The following is a description of a gene set: studied in species Homo sapiens Human Gene Set: MIR374B_3P from publication Chen Y, Wang X (PMID 31504780) Genes predicted to be targets of miRBase v22 microRNA hsa-miR-374b-3p in miRDB v6.0 with MirTarget v4 prediction scores > 80 (high confidence targets)., and this is the list of marker genes: SRRT, NPTN, CDK17, FAM135A, KANK1, CREB5, FAM169A, FAM204A, DSEL, POGZ, ZC2HC1A, SLC20A1, LRRK1, MOB4, CLPX, PRMT2, MCTS1, ASH1L, NOS1, VSNL1, NWD2 (NACHT and WD repeat domain containing 2), GAREM1, RASGEF1B, NRBP1 (nuclear receptor binding protein 1), GDPD4, ZFPM2, LCN2 (lipocalin 2), NUDT4, RPS6KA6, SP7, CMC4, JRKL, SIPA1L1, DCUN1D4, CALCR, CCDC80, FOXO1, UBR3, SPRED1, SRPRA, GRIP1, TLK1, MGAT2, FAM199X, MTF1, ZNF621, PPIG, INO80D, FMR1, TMEM70, QKI, SEC24C, FBXL3, SLC16A9, CSNK1D, KSR1, DCN, PACRG, STK33, FEZF1, ISM1, IKZF5, TMEM183A, RASSF10, SUMF1, AHSA2P, MSL3, RP2, PPARGC1A, ZNF518A, DBNDD2, PLAG1, NAA15, DGKH, ITGB1, TMOD3, PAM, EEF1AKMT2, NR2F2, QRFPR, LRRC1, ATP6V1C2, ZBTB38, CENPI, B4GALT1, HECTD1, CTCFL, GAS7, PTAR1, TMEM100, BMPR1A, ZFYVE21, ADGRL3, IPO7, MOV10 (NCBI Gene Id 57723), MLIP, SLITRK4, TAOK1, PARP8, TIPARP, TTL, SEPTIN7, GABRA2, SMAD7, BLTP3A, UBE4B, MPDZ, CLCN3, CPNE4, HTR1F (5-hydroxytryptamine receptor 1F), ARFGEF1, TMCC1, HIPK3, DDX53, DYRK1A, TFRC, TMEM30A, KCNQ5, C3orf62, VEGFA, FBXW7, SLC38A1, SH3BGRL2, ZFP82, KLHL28, SYT9, PROX1, PTPRR, MSX2, SMAD2, OPRM1, STXBP5L, DNM3, UHMK1, ZFHX3, PTPRE, SLIT2, UNC13A (unc-13 homolog A), MARCKSL1, CDH10, C1GALT1, NIPAL3, RAB14, KIF21A, LRRC19